The following is a description of a gene set: Type 1 IFNs can conditionally activate all of the signal transducers and activators of transcription molecules (STATs), including STAT4. The best-characterized signaling pathways use STAT1, however, and type 1 IFN inhibition of cell proliferation is STAT1 dependent. We report that type 1 IFNs can basally stimulate STAT1- and STAT4- dependent effects in CD8 T cells, but that CD8 T cells responding to infections of mice with lymphocytic choriomenigitis virus have elevated STAT4 and lower STAT1 expression with significant consequences for modifying the effects of type 1 IFN exposure. The phenotype was associated with preferential type 1 IFN activation of STAT4 as compared to STAT1. Stimulation through the TCR induced elevated STAT4 expression, and STAT4 was required for peak expansion of antigen-specific CD8 T cells, low STAT1 levels, and resistance to type 1 IFN-mediated inhibition of proliferation. Thus, a mechanism is discovered for regulating the consequences of type 1 IFN exposure in CD8 T cells, with STAT4 acting as a key molecule in driving optimal antigen-specific responses and overcoming STAT1-dependent inhibition of proliferation. Genes up-regulated in CD8 T cells: naïve versus day 8 after LCMV infection. Human Gene Set: GSE40666_NAIVE_VS_EFFECTOR_CD8_TCELL_UP from publication Gil MP, Ploquin MJ, Watford WT, Lee SH, Kim K, Wang X, Kanno Y, O'Shea JJ, Biron CA (PMID 22968462) species: Homo sapiens, and this is the list of marker genes: TSC22D1, TM7SF2, SLC23A2, BEND5, CHL1, CORO7, EXPH5, BRD3, IFNGR2, STAU2, TDRKH, BCL6, TNIK, AS3MT, PACS2 (phosphofurin acidic cluster sorting protein 2), MMP9, UBALD2, EPHX4, BCL7A, LEF1, MRTFB, CBX4, GPRASP2, PIP4K2A, SEC22C, TRAK2 (trafficking kinesin protein 2), ARMCX1, ZNF512, BASP1, UNC5CL, ZBTB18, FMNL3, FAM168A, XPO1, DZIP1, PBX2, HLA-DMB, CRY1, MACROH2A1, PCGF5, N4BP2 (NEDD4 binding protein 2), ZNF597, SLC12A5, RBL1, EDARADD (NCBI Gene Id 128178), BAZ2B, APBB1, ZDHHC15, ITGA8, TMEM59L, SPSB1, TULP4, SLC39A14, DNAJC10, NRIP1, PFKM, ADGRG3 (NCBI Gene Id 58870), SLC25A27, IPO11, PPP1R13B, EGR2, PRKCB, TUBB2A, MEF2D, PCM1, LXN, HMG20A, UCK2, ANO6, RBMS2, ARSI, MARCHF7, ATL1 (NCBI Gene Id 6681), NCOA5, TUBB, POGLUT2, GPRASP3, CELF5, PLIN2, GALNT6, SUSD6, TET1, MTF2, COL4A5, ARHGEF17, ZC4H2, MARCKS, THEMIS, CLCN4, LDHB, ENDOU, ZNF22, SMARCD1, SOX4, MAPK7, SALL2, MTSS1, GTDC1, CSK, ADCY6, ALDH7A1, DLG3, ARHGEF6, EML2, IKZF4, CSNK1E, ZNF608, MSH6, ZNF740, SMAD1, SLC30A4, PRMT2, NR4A3, ABI3, ING1, PLXND1, TSPAN6, DAPK1, PIK3R3, BEX1, SHF, CACNG4, HLA-DOB, DNTT, GREB1, GLCCI1, CPM, RASGRP1, TLE2, MEGF9, TOX, ITPR1, KIF23, BAIAP2, ZFYVE28, ABTB2, LRRC42, TFRC, RALGPS1, PRRG1 (proline rich and Gla domain 1), ENO2, MCU, ST6GAL1, PFN1, BACH2 (NCBI Gene Id 653980), FAM117A, OSBPL11, VANGL2, CAMK4, PHC1, MBTD1, CAND2, FIRRE, RALGPS2, CEP57L1, CALCOCO1, SELENOP, SRSF10, MAP2K6, FAM193A, UBE2E3, MPI, ADAM11, MS4A1, MAP4K5, PLOD2, FOXP1, PFN2 (profilin 2), NT5C3B, PRMT5, STRIP1, IFT81, MACO1, IL4R, ZNF799, CSGALNACT1, CLPB, APPBP2, TTC3, IPO13, SATB1, CACNB3, PTBP2, KDM5B, ACOXL, RTN4RL1, IL6ST, GPBP1, NABP1, LAT, EXT1 (NCBI Gene Id 3966), WDR35, C2orf68, TMEM164, TMCC3, LCMT1, SPATA6, MAP3K7, AFDN, ZNF467